Given this list of marker genes LRPPRC, PCLAF (NCBI Gene Id 9768), TOP2A, SMC4, NASP, SNRPD1, TCERG1, MCM7, PCNA, SUPT16H, RRM1, DKC1, NDC80, MSH6, MCM3, U2SURP, SERBP1, MSH2, FEN1, MCM6, GINS1, MLH1, USP1, ITGB3BP, RAD51AP1, RFC4, FANCI, LIG1, here is a description of the gene set: studied in species Homo sapiens Neighborhood of MSH2 mutS homolog 2, colon cancer, nonpolyposis type 1 (E. coli) in the GNF2 expression compendium Human Gene Set: GNF2_MSH2 Neighborhood of MSH2